Given this list of marker genes Tgfb1, Birc5, Mir124a-1, Cdca5, Ube2c, Phb2, Mir124a-3, Neurog1, Mir124a-2, here is a description of the gene set: species: Mus musculus Any process that activates or increases the rate of progression from anaphase/telophase (high mitotic CDK activity) to G1 (low mitotic CDK activity). Mouse Gene Set: GOBP_POSITIVE_REGULATION_OF_EXIT_FROM_MITOSIS